The following is a description of a gene set: species: Homo sapiens Human Gene Set: GSE17186_MEMORY_VS_CD21LOW_TRANSITIONAL_BCELL_DN Genes down-regulated in B lymphocytes: memory versus transitional CR2 low. from publication Suryani S, Fulcher DA, Santner-Nanan B, Nanan R, Wong M, Shaw PJ, Gibson J, Williams A, Tangye SG (PMID 19965666) Goals/objectives: to identify various gene expression in B cell subsets derived from human PBMC and cord blood, and this is the list of marker genes: RPS8, ARHGAP9, CDC25B, GNGT2, ENO1, KCNH3, EFNA2 (NCBI Gene Id 1943), LAS1L, AKAP12, IBTK, PTPN2, SERTAD3, SEC62, B4GALT1, SLC24A4, ARHGEF1 (NCBI Gene Id 9138), NFATC1, TBC1D12, NFKB2, TMEM223 (transmembrane protein 223), BCL10, NELFB, SNX9, SUSD1, EIF5, CASP4, SPESP1, ZNF622, USP24, RFXANK, KDM4B, RP9, DNAJC17, ASTE1, FOXO4, DCP1B, PMS2, CSK, CABP2, ZNF317, CAND2, SMARCD2 (NCBI Gene Id 6603), IRF2BPL, HES5, ZFP14, C19orf38, NEU1, TMEM39B, CHRNA5, ADD1, MTERF2, SNX33, STING1, STK24, PIAS4, EFS, POMT2, EMILIN2, SNAP29, CD53, MSN (NCBI Gene Id 4478), CIPC, SCML4, IRGQ, DDX24, PARP16, FAM32A, KCNC3, C9orf85, TRMT112, HOPX, HPSE, GALNT6, DDX54, TEX264, ARAP2, BBS9, KCNJ1, SNX2, COX11, PPM1E, CKAP4, KCNK5, CARD11, S1PR4, BMAL1, TRAF3IP3, H2AJ, GCOM1, ACBD4, C12orf43, FSCN3, HMGCS1, KLF13, RBM28, TIGD2, BUD23, GPN3, GPAM, B4GALNT1, KRT10, MDP1, CDK5R1, PRSS12, XRCC5, POU6F1, TCF12, SLAIN1, PRF1, TASL, NUDCD1, INPP5F, ANKRD37, ZNF2, LAMC1, SLC25A53, BCL3, MEX3A, TRNT1, DMPK, KDM2A, TUT4, RRM2B, ZFP36L1, RPL35, LAMP1, USP30, BCL2L12, LRPPRC, PRKCB, DNAJC9, MTNAP1, DNAJC4, METTL23, BCDIN3D, TUT1, INSL6, ATP13A5, SLC2A1, ZSWIM1, SNRPG, GBA2, OVGP1, FYTTD1, PRKAG1, STK17B, ATP5F1D, DCAF1, POC1B, RSF1, SIDT1, JAK1, TFAM, POLR3GL, TGIF2, ADPRM, CSNK1G2, SPECC1L, UTP14A, RAB3GAP1, BCL11A, MTCP1, TTI2, PDCD4, NELFCD, ELF1, B3GNT5, CFLAR, TREML2, BTD, APCDD1, CEP97, ALKBH8, ADGRD1, MAP7, ATP6AP1, PITPNM2 (phosphatidylinositol transfer protein membrane associated 2), EEF1G, SELL, TACSTD2, NLRP10, RECQL5, KAT8, SELENOP, RNF144A, DPH7, AQR, CNP, C8orf33, ATP2A3, EXOSC10, ZNF239, MGST2, STEEP1, PRM2, AOPEP, ARFGAP1 (NCBI Gene Id 55738), PCBP4, NUDT16L1